Given this list of marker genes DAPK1, KLHL22, HAVCR2, IL12B, PRKAA1, PDCD1, NECTIN2, CD274, HRG, IL12A, CEACAM1, SLC22A13, YWHAG, HLA-DRB3, HLA-DRB1 (NCBI Gene Id 730415), HSPD1, GSDME, USP5, CD160, IL4I1, MAPK3 (NCBI Gene Id 5595), MR1, PVR, HMGB1 (NCBI Gene Id 3146), AHR, CRTAM, UFL1, CD226, TGFB1, FBXO38, here is a description of the gene set: studied in species Homo sapiens Any process that modulates the frequency, rate, or extent of a response to tumor cell. Human Gene Set: GOBP_REGULATION_OF_RESPONSE_TO_TUMOR_CELL